Given this list of marker genes MAPK13, HNRNPA1, ZC3H12A, DAXX, HSF1, XPO1, here is a description of the gene set: species: Homo sapiens Any process that results in a change in state or activity of a cell (in terms of movement, secretion, enzyme production, gene expression, etc.) as a result of a salt stimulus. Human Gene Set: GOBP_CELLULAR_RESPONSE_TO_SALT